Given this list of marker genes CCDC40, OFD1, KIF27, WWP2, NEK10, SPAG17, RFX3, DNAAF4, ODAD3, NHERF1, DNAI1, DNAH9, GMNC, CCDC88C, SPA17, DPCD, NME5, DAW1, CABYR, CFAP43, ARRDC1, DNAAF2, AQP4, JHY, CCDC39, CFAP53, DNAAF3, CCDC103, DNAH1, CFAP45, STK36, DNAH5, CWH43, ADCY10, RSPH4A, KATNIP, ROPN1L, VANGL1, DNAAF1, CFAP54, DNAAF11, NME7, DNAH11, ODAD4, TTLL1, DRC1, TSG101, CFAP221, SPAG6, NPHP3, GAS8, SPEF2, SPAG16, STARD7, here is a description of the gene set: The transport of substances that occurs outside cells. Human Gene Set: GOBP_EXTRACELLULAR_TRANSPORT species: Homo sapiens